Given this list of marker genes Csnk1e, Ttc34, Rassf6, Megf11, Ezh2, Trpc3, Arrb2, Spn, Eng, Adcyap1, Glp2r, Aldh4a1, Vangl2, Nup133, Gm5142, Wdr46, Grip1, Cacnb3, Gjb1, Cacng5, Hsd17b13, Prdm16, Papola, Cnot1, Efemp1, Tnrc6b, Chd1, Ddx10, Slc38a2 (solute carrier family 38, member 2), Cttnbp2nl, Aoah, Etv1, Tnpo2, Stard4, Sorcs2, Rnf14, Col1a2, here is a description of the gene set: Genes predicted to be targets of miRBase v22 microRNA mmu_miR_6393 in miRDB v6.0 with MirTarget v4 prediction scores > 80 (high confidence targets). species: Mus musculus Mouse Gene Set: MIR_6393 from publication Chen Y, Wang X (PMID 31504780)